The following is a description of a gene set: studied in species Mus musculus Any process that activates or increases the frequency, rate or extent of the chemical reactions and pathways resulting in the formation of prostaglandin. Mouse Gene Set: GOBP_POSITIVE_REGULATION_OF_PROSTAGLANDIN_BIOSYNTHETIC_PROCESS, and this is the list of marker genes: Avp, Anxa1, Pla2g3, Ptgs2, Avpr1a, Cd74, Mapk9, Pla2g4a, Il1b